Given this list of marker genes Enoph1 (NCBI Gene Id 97253), Car9, Gchfr, Bag4, Snapc2, Commd4, Dgkz, P3h1, Atp13a1, Gcc2, Wdr62, Grk4, Enpp4, Phc1, Nat8f1, Ankib1, Lsm1, Cyp20a1, Tmem208 (transmembrane protein 208), Fndc3a, Chek1 (NCBI Gene Id 97555), Rfx2, Zfp128 (zinc finger protein 128), Rbm15, Tmem67, Samd14, S100a6, Lzts3, Pde4dip, Duox2 (NCBI Gene Id 279020), Ovol1, Raver1, Sf1, Glb1l, Fbxl17 (NCBI Gene Id 76180), Rap2a, Ormdl2, Ptprs, Cox5b, Slc25a26, Psen2, Vps53, Wbp11, Pate2, Parp11, Crnde, C2cd3, Nol8, Ugdh, Cldn3, D930032P07Rik, Gjc1, Hyls1, Mzt2, Large1, Zmym3, Snai2, Mybl1, 1700040D17Rik, Snrpa1, Mtbp, Sf3b1, 4930594M22Rik, Snx17, Calm2, Tmem74, Snhg6, Nop58 (NCBI Gene Id 55989), Aifm1, P4ha1, Ikbip, Tdrkh, Abitram, AU022252, Rpgrip1l, Dtymk, Cct4, Myl4, Gm15246, Mri1, Atp10a, Mm2pr, Fhod1, Trim35, Cmbl, Mapre2, Gm12279 (predicted gene 12279), 2700049A03Rik, Wnk1, Dut, Aldh6a1, H2ac10, Ccng1, Akt2, Zhx2, Mrps24, Mmachc, Idh1, Cops8, Eif2b4, Wdr7, Tacc3, Qki, 9630013D21Rik, Cyb5d1, Zdhhc4, Penk, Rmnd5a, Vim, Capns1, Pih1d1, Gm15473, Dnajc4, 4930467K11Rik, Ttbk2, Zfp866, Atrip, 1700056E22Rik, Rptor, Amotl1, Pcyox1l, Camta1, Gm27042 (NCBI Gene Id 102636239), Nkrf, Fth1, Fermt1, Hjurp, Bivm, Irf1, Fut8, Ppp6r3, Stag1, 1700113A16Rik, Cbr2, Eloa, Tmbim6, Plk2, Yars2, Coq7, Mtmr3, Ubn2 (ubinuclein 2), Tpp2, Wrap73, Ube2z, AI987944, Matr3, Mix23, Tmem218, Ggt7, Lrrfip2, Isg20, Erp44, Ap1m1 (NCBI Gene Id 11767), Med26, Maz, Adrb2, Apaf1, Mtmr2, Dhrs1, Cactin, Rassf1, Abca8b, Sod2, Trappc3 (trafficking protein particle complex 3), Fkbp14, Ndufaf1, Lrrc8a, Snord61, 1810055G02Rik, Cdc27, Tmem126a, Rmrp, Cfap43, Syvn1, Dis3, Ftl1, Ppme1, Arhgap35, Scp2, Cenpc1, Tlcd3a, Adgrl1, Tgfbr2, Arl6ip5 (NCBI Gene Id 93796), Smg9, Lin52, Nedd8, Skp1, Dcaf11, Sfpq, Rassf3, Zfp568, Tm4sf1, Zfp473, Anxa6, Emp3, Trim47, Syngr4, Snx1, Flywch1, Specc1, Gm14966, Engase, Zfp959, Mtf1, Azin1, Mrpl18, Sh2b3, Ino80e, 4930581F22Rik (RIKEN cDNA 4930581F22 gene), Smcr8 (NCBI Gene Id 69685), Focad, Gm15559, Mysm1, Gm6822, Erc1, Zfp689, Naa38, Aldh18a1, 4930589O11Rik, Myh14, Ifnar2, Rgs12, Gmfb, Mir30a, Surf6, Gm14137, Crb3 (NCBI Gene Id 224912), Git2, Tceanc, Atg4a, Cep170 (centrosomal protein 170), Lats1, Asf1b, Dnaaf1, Golim4, Stk16, 6530401F13Rik, Plekhj1, Rad51b, Egln2 (egl-9 family hypoxia-inducible factor 2), Rbm38, Rnf44, Slc12a9, Fdxr, Nop14, Pip4k2a, 5730455P16Rik, Tecpr1, Psat1, Zfp865, Dusp10, Gpr137, Prpf19 (pre-mRNA processing factor 19), Acadl, Ankrd28, Plekho1, Cep20, Pogz, Sucla2, Spc24, Mlph, Mageb3, Stard6, Tmem184c, Gfpt1, Kctd7, Espn, Bad, Sowahc, 0610040B10Rik, Nusap1, Mpc2, Emc3, Fads1, 2310058D17Rik, Mex3b, A130010J15Rik, Hccs, Snx32, Fhl4, Cstf1, Spg7, Tnrc6b, Wdcp, G630030J09Rik, Rasa4, Sgms2, Zkscan5, Tmem216, Tyms (NCBI Gene Id 22171), Gpr108, Slc16a1, Hdgfl2, Fam216a, Usp42, Il6, Armc9, Arl4d, Yy1, Rbm43, Slc25a19, Ppat, Angptl2, Ovol2, Timm9, Ankfy1, Pcyt2, Rpl41 (ribosomal protein L41), 4930577N17Rik (NCBI Gene Id 67746), Zfp667, Ctnnbl1, Zc3h6, Slc7a6, 4932412D23Rik, St3gal4, Sec62, Ciao2a (NCBI Gene Id 68250), Fem1c, 5033403F01Rik, Mrpl13, 1700001G11Rik, Slx4, Ppm1g, Setd3, Prelp (NCBI Gene Id 78098), Evi5, Calm1, Akr1b1, Ccdc88a, Cir1, Necap1, Gm16230, Ipo9, Mir8111, Cep85, Fam161a, Fen1, Gmpr2, Smim19, Sdccag8 (NCBI Gene Id 76816), Gm2822 (predicted gene 2822), Gss, Cycs, St3gal2, Acot2, Setd1a, Suox, Npc2, Usp10, Abt1, 4933431K23Rik, Rnd1, Zcchc8, Opn3, Tcaim, Ctdspl2, Gm17102, Rlig1, Sacs (NCBI Gene Id 50720), Tcp1, Zfp395, Gk5, Diablo, Ahdc1, Msn, Aurka, Tprkb, Lrrc28, Ypel3, Gm9967, Pgp, Gan, Pik3ip1, Mrpl50, Ankrd26, Dtwd2, Gpr19, Ankrd1, Zeb1os1, D830025C05Rik, Krit1, Apeh, Ccnk, Mesd, Pwp2, Tesk2, Top3a, Kpnb1, Gne, Adnp, Prnp, 1700017B05Rik, Dtx4, Pwwp2a, Dcaf7, Ubb, Arfgap3, Lix1l, Prn, Atf1, Taf1b, Cybc1, 9530068E07Rik, Asb1, Entpd1, Mapk1ip1l, Ppp1r3f, Nfya, Fxyd2, Rdh11, Duoxa2, Paics, Phip, Ube2f, Chmp1a, Gm26787, Elf2, Ep400, Ddx31, Spdya, Slc38a2, Mir7671, H4c12, Stt3a, C230035I16Rik, Ywhah, Zbed3, Lratd2, Zcchc24 (zinc finger, CCHC domain containing 24), Pnrc1, Ireb2, Ubl5, Ndufa6, Gm17213, Sox11, Mfsd14b (NCBI Gene Id 66631), Zbtb20, Slc35a1, Aldh16a1, Prkacb, Helz, Spred1, Ccdc163, Mturn, Ppp1r12c, Plec, Ado, Mapk8ip2, Zfp787, Lrig3, Rps6kl1, Ints6l, Fhip1b, Mphosph9, Loxl4, Fut10, Rbm14, Marchf6, Capn7, Skap2, Fancd2, Katnal1, Ric8b, Flicr, Xkr8, Mtr, Tspyl1, Urod, 4930503L19Rik, Rnf10, Adh5, Gamt, Fto, Snai1, Cbll1, A730061H03Rik, Cfap97, Pigv, Elp4, Nom1, Srebf2, R3hdm1, Tmem230, Ggct, Glt28d2, Abcg2, Cdan1, Gm4473, Cyth2, Iftap, Cdkl5, Phf1, Tmem266, Fam72a, 4930426L09Rik, Bbs10, Zfp346, Tollip, Tnc (tenascin C), Ppp4r3b, Emb, Ube2s (ubiquitin-conjugating enzyme E2S), Zmat1, Tbp, Zfp956, Nup205, Cdc42, Zranb3, Slc30a5, Pknox1, Ccdc28a, Pip4p1, Gm11205, Tuba1b, Lgals8, Hirip3, Cdk12, Dcaf6, 6330562C20Rik, Ttc7 (tetratricopeptide repeat domain 7), Hip1, Wdr35, Gpn3, B9d2, Zkscan8, Dmwd, Impa1, Eny2, Rgs20, Tiprl, Inka1 (NCBI Gene Id 68176), Snrpb, Slc29a1, Ap4m1, Vcf1, Tctn3, Fbxl12, Cfl1, Cdh2, Arfip1, Hmgb1, Trim11, Cox5a, Ppp1r35, Rpa3, Kmt2a, Cyb561, Unc50, Micos10, Tmem263, Snap23, Cdc42bpa, Pakap, Pias4, Epop, Cracr2b, Gclm, Gm10644 (NCBI Gene Id 100126034), Mul1, 5430402O13Rik, Oard1 (NCBI Gene Id 224841, O-acyl-ADP-ribose deacylase 1), Las1l, Smyd5, Mtrfr (mitochondrial translation release factor in rescue), Arhgap22, Zbtb41, Phf3 (PHD finger protein 3), Pus10, Jmjd1c, Gtpbp3, Mettl5, AV039307, Tes, Srgap2, Pdzd8, Prkar1a, Oip5, Tmem143, Vps35l, Zfp566, 1700028E10Rik, Reps1, Cep135 (NCBI Gene Id 381644), Inpp4a, Coa5 (NCBI Gene Id 76178), Scoc, Mtnap1, Vrk3, Zfp608, Hexd (NCBI Gene Id 238023), Zfp382, Paxbp1, Zfyve26, Pspc1, Pltp, Hsdl1, Nfatc2, Mcm7, Cenpp, Rdh1, Ate1, H3c11, Hnrnpdl, Gm21992, Cdh24, Prmt6, Plekhh2, Kansl2, Xbp1, BC049715, Slc9a5, Wbp2, Prss22, Rpl10, Zfp1, Tmem258, Uhrf2, Zfp784, here is a description of the gene set: from publication Yevshin I, Sharipov R, Kolmykov S, Kondrakhin Y, Kolpakov F (PMID 30445619) studied in species Mus musculus Mouse Gene Set: OVOL2_TARGET_GENES Genes containing one or more binding sites for (Ovol2) in their promoter regions (TSS -1000,+100 bp) as identified by GTRD version 20.06 ChIP-seq harmonization.